The following is a description of a gene set: from publication Buytaert E, Matroule JY, Durinck S, Close P, Kocanova S, Vandenheede JR, de Witte PA, Piette J, Agostinis P (PMID 17952126) species: Homo sapiens Genes up-regulated in T24 (bladder cancer) cells in response to the photodynamic therapy (PDT) stress. Photodynamic therapy (PDT) is an anticancer approach utilizing a light-absorbing molecule and visible light irradiation to generate, in the presence of O(2), cytotoxic reactive oxygen species, which cause tumor ablation. Given that the photosensitizer hypericin is under consideration for PDT treatment of bladder cancer we used oligonucleotide microarrays in the T24 bladder cancer cell line to identify differentially expressed genes with therapeutic potential. This study reveals that the expression of several genes involved in various metabolic processes, stress-induced cell death, autophagy, proliferation, inflammation and carcinogenesis is strongly affected by PDT and pinpoints the coordinated induction of a cluster of genes involved in the unfolded protein response pathway after endoplasmic reticulum stress and in antioxidant response. Analysis of PDT-treated cells after p38(MAPK) inhibition or silencing unraveled that the induction of an important subset of differentially expressed genes regulating growth and invasion, as well as adaptive mechanisms against oxidative stress, is governed by this stress-activated kinase. Moreover, p38(MAPK) inhibition blocked autonomous regrowth and migration of cancer cells escaping PDT-induced cell death. This analysis identifies new molecular effectors of the cancer cell response to PDT opening attractive avenues to improve the therapeutic efficacy of hypericin-based PDT of bladder cancer. Human Gene Set: BUYTAERT_PHOTODYNAMIC_THERAPY_STRESS_UP, and this is the list of marker genes: PSG7 (NCBI Gene Id 5676), SBNO1, SLC1A4, HSP90AA1, RSC1A1, NCOA1, TANK, EIF5A2, SCG5, PWWP3A, TVP23B, SPTLC2, HOXD1, GCLC, KMT2B, IKZF5, TMEM39A, GK, ZNF24, SERPINB2, ABHD3, PMAIP1, RAB29, FOXO3, CEP112, XIAP, PALLD, GMFB, GOLGB1, VCPKMT, SLC30A1, SIM2, SENP5, RB1CC1, EGLN2, N4BP2L2, BTN3A3 (butyrophilin subfamily 3 member A3), SLC2A3, DNAJB6, FZD7, LARP6, NUMB, HUS1, IP6K2, PLEKHF1, FNBP4, CLDN14, WDR47, SERPINH1, CUL3, NCOA6, UTP25, BAZ2B, MID2, KLF11 (NCBI Gene Id 8462), IRF1, EEIG1, NRF1, SFPQ, KLF12, PTHLH, PRKCD, RRAS2, ATF7IP, GABARAPL1, PLEKHM1, RNF44, NIPBL, R3HCC1L, SNIP1, MORC3, GADD45A, LMBR1L, FTH1, ATG14, WDR48, CIR1, GCLM, RWDD2A, POU2F1, KDM2A, KLF6, HMOX1, KITLG, NR1D1, RNF38, TSC1, RNF103, UPF3B, FOS, NAB2, CPT1A, DYRK3, FKBP4, GOLPH3L, LARP4, PSG6, HIPK3, SLC25A38, KDM6A, RHOQ, LOX, ZNF274, PALM2AKAP2, MAP3K14, ZNF394, RND3, POR, RRAGD, RP2, RAB11FIP1, GPRC5B, RHOF, SLC25A36, YPEL5, KDM6B, RTN2, SYF2, TFPI, GEM, RAB5A, HIVEP2, TSPYL2, CCDC68, ABHD5, ARPP19, ING1, N4BP1, SQSTM1, PSPH, ZNF354A, H2AC18, OSER1, RCAN3, ZCCHC14, ETS2, NAV2, BHLHE40, AFF4, PLXNA3, CNNM4 (cyclin and CBS domain divalent metal cation transport mediator 4), MED13L, TMCC1, NFKBIA, USP36, KHDRBS1, UBE2B, PER3, ZNF143, CDKN1C, PDE4DIP, BRD1, OASL, BRWD1, SEC24A, FBXL12, SYNGR3, GNA13, SRSF11, SNAP23, MMP13, ELL, DLGAP4, PAFAH1B1, ZNF282, AK6, LAMTOR3, VEGFA, IBTK, AXIN1, MAP3K2, GPRC5A, PFKFB3, TLE1, UBR2 (NCBI Gene Id 255838), PLEKHO2, HPGD, ATP6V1B2, ARHGAP45, DCP1A, IRS2, FOXJ3, MAP1S, SOS2, PI4K2A, MTHFD2, SNN, ZNF84, FBXO38, RYBP, APPBP2, NPIPA1, GDF15, SLC3A2, DHX34, NEU1, ILRUN, SENP6, GPR137B, PTX3, KDM4A, GPATCH3, ZBTB40, TTC17, SOCS1, MARCHF7, EIF4EBP3, WBP4, GON4L (gon-4 like), TJAP1, GPR107, ZFP36, SOD2, TICAM1, PRDM10, BTN2A2, GGPS1, SETD2, CXCL8, FEM1C, AHNAK2, MTF1, MT1X, PKD1, GSE1, AHSA1, TMED5, JMJD1C, SLC39A14, CSNK2A1, RCAN1, ZNF442, SPAG9, DHRS3, DDAH2, HSPD1, TCF7L1, RSRC2, ZMYM5, DNAJA1, GJC1, CCNJ, EFNA4, BPGM, RAB6A, KLF3, DCTN4, RIOK3, CDR2, IRF9, STK10, ATP6V1C1, DAAM1, NUP58, LHFPL2, RELB, TOB2, PHF1, IL13RA2, ZNF473, ATP2B4, TP53BP2 (tumor protein p53 binding protein 2), ZNF322, HERPUD1, SAT1, GTF2IRD1, CSTF3, FAM169A, ARID3B (AT-rich interaction domain 3B), IL6R, RNMT, COQ10B, BTG1, IST1, RABGGTB, FGF2, DUSP5, RBM48, FAM53C, CHKA (choline kinase alpha), MTPAP, MAP1LC3B, ZNF254, ZNF395, STX3, ZC2HC1A, SEC24D, TRIM23, RLF, MAP3K9, PPP2R5B, PRDM4, LRIF1, CSF2, GCC1, SLF2, SPSB1, TBC1D15, PJA2, KIN, LSS, KLF5, INSR, NFIL3, BTN3A1, STC2, MAPK7, CDK17, SORBS1, KCNK1, MTMR3, RABEP1, HIC2, AKAP8L, GNAI3, ZEB2, EIF2AK3, MTUS1, MSX1, GFPT1, WIPI1, KIZ, CSNK2A2, VPS37B, TCEAL9 (transcription elongation factor A like 9), RNF19B, CXCL2, PTP4A1, RBM25, RAB22A, CCNL1 (NCBI Gene Id 57018), RBM39, GRB10, HMBOX1, CDKN2AIP, DENND4C, HIVEP1, RALGDS, CLCF1, ORC6, N4BP2L1, EIF5, ACVR1B, PAX8 (paired box 8), PPP1R15A, TRIB3, SPRY2, AP3S2, LIN37, UPP1, ZBTB43, MFHAS1, FTL, DNAJB2, ZNF277, HSPBAP1, STAG2, PNISR, TOB1, LCOR, CLK4, PELO, SREK1, RSF1, HECA, SYNC, SFSWAP, H2BC5, PLIN2, DNAJB1, EIF3A, TXNL4B, BACH1, CSGALNACT2, HSF2, RGPD5, KLF4, NFAT5, CCN3, CHORDC1, CNIH3, RNF6, GPR161, ARIH1, TXNRD1, CHIC2, IL18, DNMT3B (DNA methyltransferase 3 beta), LGALS3, ITSN2, HSPA6, GMEB2, DYNC1LI1, AMPD3, AADAC, TRMO, LDAF1 (lipid droplet assembly factor 1), TCF20, DNAJB14, IQCB1, SMC5, PPARG, RASAL2, AHI1, TSC22D2, ZMIZ1, ADNP2, TBC1D17 (TBC1 domain family member 17), HBP1, MRPL18, ZNF426, ELK4, PRRC1, JMJD6, ATF4, PLA2G4A, MKRN1, PER1, BMP2, INPP5E, STK17B, TTC33, TBC1D3F (TBC1 domain family member 3F), WAC, IP6K1, GOLGA5 (golgin A5), ABCA1, HSPA13, ATP6V0A2, GTF2B, PGM3, AP1AR, GSK3B, PRRC2B, ACVR1, BRD2, CDKN1A, ELF1, TRAF6, KHNYN, CNOT4, PIM1, MEF2D, GTF2H1, PGF, PTBP2, PPIF, CDKL3, LYST, HDAC5, SKIL, RHBDF1, CLIP2, RAB40B, SLC4A7, AZI2, UFM1, DNAJB9, RAB9A, OSGIN1, ZNF165, GAREM1, WRN, FRS2, MAFG (MAF bZIP transcription factor G), ULK1, ZFX, TFPI2, EIF1, RELN, RSL1D1, NCF2, MLF1, ZNF212, F2RL1, IL6, SLC33A1, P4HA2, PTGS1, ADAM17, SP2, TUBB2A, TRIM13, TNFSF9, RIT1, UBXN7, C3orf52, SLK, SOS1, HERC4, GMEB1, ADCY7 (adenylate cyclase 7), TANC2, UBAP1, HRH1, LZTS3, NRBF2, PDE10A, PLCD1, PSEN1, FNTA, AP5Z1, NDRG1, NUP50, CUL7, ST3GAL6, OSBP, NSMAF, CCNT2, FGD6, HSPA4L, PKNOX1, WASHC2C, GOLGA2, PMP22, ZNF557, PLAGL2, INHBA, PSG1, WDR19, BAG3, ZNF16, SRC, ARHGEF2, OPTN, UAP1L1, CDK8, SNX6, NUDT4, CHTOP, ARID4B, UBE2Q2P1, RIPK2 (receptor interacting serine/threonine kinase 2), STXBP3, ZSCAN5A, UBE2D1, NRG1, THBD, CCNA1, NCOA3, MARCHF6, CGRRF1, ITGA2, NXF1, SPSB3, CDK19, CREBBP, NAMPT, ZNF140, CCSER2, IL1A, TNFRSF11B, ANXA10, PPL, RABGAP1, ACVR2A, TOPORS, SLC38A2, AKAP17A, TLR2, SLC38A7, NFE2L2, KDM3A, GPATCH8, WIPF2, MXD4, SMAD4, RPS6KA5, HAUS6, RAD54B, ZKSCAN5, CITED2, FGFR1, PRKD2, ATXN3, ARL8B, KIF3C, CUX1 (cut like homeobox 1), EREG, RMND5A, PSG9, GNAI1, JUND, BET1, HSPH1, RGL1, KPNA5, MAP4K3, NR1D2, SGPL1, MEGF9, PRRG4, TJP1, TCF7L2, PSG4, HS1BP3, SLC7A11, IRF7, H2AC6, ZC3H12A, OSBPL2, SERP1, ATF2, ANKRD12, DDIT4, KLHL24, CBLL1, IGFBP1, PLEKHB2, TRIM16, CEBPB, SEC24B, HEY1, EP300, RAB7A, BRAP, SIRT7 (NCBI Gene Id 51547), RHOB, RALGAPB, SNX16, TRIM36, VPS4B, EZH1, RSAD2, DST, H2BC12L, TXNIP, RRAD, TRIB1, RAB8B, CCDC93, KLF10, ABL2, RPS6KC1, ABCC5, SHTN1, NR2C2, LRIG2, MMP1, LUC7L, PCNX1, ZC3H7A, ACBD3, SETD5, BAHD1, DNPEP, SWAP70 (NCBI Gene Id 23075), MAU2, PIAS4, SIK1, ARFGEF2, PER2, RIPOR1, IER3, NPC1, ARMCX3, HSP90AB1, ANKRD10, AKR1C1, UBE2H, CDC42, PLA2G15, CENPJ, RRAGC, LRRC8E, TRIM25, DUSP10, TRIM33, PDZD2, ZSCAN31, GARRE1, FEM1B, IL15, CEBPG, DUSP1, PUM1, CYTH2, RGS17, MBNL2, WSB1, CLU, STAM (NCBI Gene Id 8027), MAP4K5, PNRC1, FA2H, WDFY3, GABPA, ARMCX2, MAFF, OGA (NCBI Gene Id 23375), AGO3, UBL3, IFI16, SLC6A6, ABTB2, ENTREP1, ZHX2, DCUN1D2, NFYA, KLF9, F11R (F11 receptor), DOK4, CD55, IL11, COPS2, BTN2A1, FICD, CTNS, VAT1, STK3 (serine/threonine kinase 3), BRF2, SLC17A5, SMOX, MBP, PTGS2, ASS1 (NCBI Gene Id 445), SIRT1, RASSF1, NDEL1, MYO9A, LYPD3, SLCO4A1, PLK3, BSDC1, MED17, UPF2, SLC6A8, IGF1R, GPBP1L1 (NCBI Gene Id 60313), CBFA2T2, BRD4, MARK3, RESF1, PPP2R2A, CSNK1G1, HSPA4, CCDC28A, KDM4B, HSPE1, TFDP2, UGDH, ADAMTS5, CXCL3, CDYL, ZNF202, TSC22D1, CELF1, PDCD4, CBLB, RCBTB1, ATP2B1, DNAJB4, FOSL2, AREG, AARS1, BAZ2A, YRDC, ARMCX6, AKR1C3, FXR1, ZC3HAV1, TMF1, RABGEF1, PLPP1, GNPDA1, WAPL, MKNK2, ARHGEF7, CTH (cystathionine gamma-lyase), SERINC1, HINFP (NCBI Gene Id 25988), TGDS, NPIPB3, GTPBP2, NAP1L1, AKAP9, AHR, TTBK2, STX1A, ARHGEF3, PHF3, ABI1, STX5 (NCBI Gene Id 6811), SLC31A2, MMP10, DSE, PIK3CA, ATF3, ARHGAP12, THUMPD2, SECISBP2L, H2BC7, CHAC1, ITCH, CAMTA2, TIPARP (NCBI Gene Id 25976), DDIT3, SMURF1, RETREG2, USPL1, PTBP3, NOTCH1, DMTF1, CDR2L, UGCG, RGS2, CLK1, MKLN1, CCNG2, SLC12A7, MXI1, SIK3, IL24, ZNF83, CEBPD, MEF2A, ARFGAP3, FAM13A, NRAS, CLCN6, MRTFA, KDM5B